The following is a description of a gene set: Mouse Gene Set: GOBP_CARBOHYDRATE_TRANSPORT studied in species Mus musculus The directed movement of carbohydrate into, out of or within a cell, or between cells, by means of some agent such as a transporter or pore. Carbohydrates are a group of organic compounds based of the general formula Cx(H2O)y., and this is the list of marker genes: Slc2a9, Irs1, Aqp7, Mfsd2b, Crebl2, Slc2a5, Enpp1, Slc2a10, Slc50a1, Slc2a1, Aoc3, Grk2, Pea15a, Cd2ap, Smim43, Tert, Sorbs1, Erbb4, Slc27a1, Slc5a4b, Rap1a, Slc45a2, Tsc2, Aspscr1, C3, Gh, Irs2, Aqp9, Gpc3, Klf15, Slc26a5, Trib3, Fabp5, Oga, Slc2a7, Gsk3a, Stxbp4, Slc1a2, C1qtnf12, Hnf1a, Itln1, Slc45a1, Tnf (tumor necrosis factor), Slc2a8, Mfsd2a, Rasa1, Drd1, Tsc1, Septin7, Fgf21, Sirt6, Slc27a4, Ednra, Slc45a4, Ins2, Opn3, Mapk14, Aqp2, Sesn2, Slc5a10, Erfe, Fgf15, Appl2 (NCBI Gene Id 216190), Ins1, Ffar4, Tmem144, Gip, Inpp5k, Clip3, Slc23a1, Adipor2, Grb10, Slc45a3, Slc2a6, Slc23a2, Rtn2, Myc, Appl1, Pou4f2, Lep, Insr, Mfn2, Sh2b2, Slc25a27, Rps6kb1, Rab4b, Capn10, Prkci, Dhrs7c, Il1b, Prkcb, Mef2a, Ace, Ctns, Ak1, C1qtnf2, Erbb3, Slc2a3, Edn1, Slc2a4, Trarg1 (trafficking regulator of GLUT4 (SLC2A4) 1), Cers1, Ostn, Sort1, Akt1, Aqp11, Adipoq, Repin1, Ahi1, Zdhhc7, Sgcb, Ocln, Smpd3, Slc2a12 (solute carrier family 2 (facilitated glucose transporter), member 12), Acacb, Hk2, Yes1, Slc5a4a, Pid1, Osbpl8, Rhoq, Selenon, Pth, C2cd5, Slc5a2, Aqp3, Nfe2l2 (nuclear factor, erythroid derived 2, like 2), Prkca, Ptpn11, Prkcd (protein kinase C, delta), Slc5a1 (solute carrier family 5 (sodium/glucose cotransporter), member 1), Slc2a2 (NCBI Gene Id 99576), Nr4a3, Upk3b, Braf, Mfsd12, Met, Akt2, Stxbp3, Rnasel, Slc5a3, Esr1, Abcb11, Igf1, Aqp1, Slc26a6